Given this list of marker genes Jun, Klf6, Hspa1a, Junb, Ltb, Jund, here is a description of the gene set: Mouse Gene Set: CUI_TREG_OSM_RESPONSE_DN Genes negatively differentially expressed in cell type: Treg upon treatment with cytokine: OSM in mouse lymph nodes in vivo. Cytokines mediate cell-cell communication in the immune system and represent important therapeutic targets. A myriad of studies have highlighted their central role in immune function, yet we lack a global view of the cellular responses of each immune cell type to each cytokine. To address this gap, the authors created the Immune Dictionary, a compendium of single-cell transcriptomic profiles of more than 17 immune cell types in response to each of 86 cytokines (>1,400 cytokine-cell type combinations) in mouse lymph nodes in vivo. A cytokine-centric view of the dictionary revealed that most cytokines induce highly cell-type-specific responses. For example, the inflammatory cytokine interleukin-1β induces distinct gene programmes in almost every cell type. A cell-type-centric view of the dictionary identified more than 66 cytokine-driven cellular polarization states across immune cell types, including previously uncharacterized states such as an interleukin-18-induced polyfunctional natural killer cell state. from publication Cui A, Huang T, Li S, Ma A, Pérez JL, Sander C, Keskin DB, Wu CJ, Fraenkel E, Hacohen N (PMID 38057668) species: Mus musculus